Given this list of marker genes Vim, Ccl9, Ptn, Chl1, Nefl, Id4, Arhgdib, Rab38, Vcam1, Bgn, Adcyap1, C1s1, Fst, Klk1, Cyp1b1, Aebp1, Nol3, Stk17b, Irgm2, Pnliprp2, Tnfaip2, Nr2f1 (nuclear receptor subfamily 2, group F, member 1), Tspoap1, Fstl5, Tgm2, Serpina9, Galk1, Dusp26, Ccl2, Notch2, Map4, Adcy7, Hcn1, Msn, Ifit2, Dnm1, Sytl3, Iigp1, Stmn2, Lgals3, Anxa2, Col18a1, Cidea, Anxa1, Cdh11, Kcnip4, Camk4, Ly6h, Ccn4, Csf1, Serpinh1, Grm7, Dkk3, Vip, Slc15a3, Fbn1, Col6a1, Kcnd2, Gab1, Pygb, Parp3, Pmp22, Tgtp1, Efemp2, H2-Aa, Cxcl12, Htra1, Cnr1, Gbp3, Dclk1, Postn, Cacng5, Ceacam10, Lgals1, Akap12, Fads3, Elavl2, Efemp1, Scara3, Maf, Atf3 (NCBI Gene Id 11910), Hps1, H2-D1, Mcam, Ifitm1, Lyz1, Abcc3, Plcb4, Ntm, Tgfb2, Pcdh15, Rnase1, Dpt, Spink1, Thbs2, Rhoc, Snca, Nrsn1, Serpine2, Mical1, Adcyap1r1, Gsta4, Oplah, Acot7, Ptpro, Itga7, Blvrb, Epha5, Ifitm3, Nebl, Col5a2, Slc16a1, Zfp521, Smad3, Pla2g4a, Sycn, Ctsc, Timp2, Ndrg2, Septin4, Sparcl1, Snai2, Laptm5, Plxnd1 (NCBI Gene Id 67784), Ms4a4d, Fgf13, Gucy1a1, Cyba, Fgf14 (fibroblast growth factor 14), Stxbp5l, Apoe, Ass1, Itgb2, Ly6a, Sema4f, Sox2, Cplx1 (complexin 1), Slc6a15, Epb41l2, Gap43 (growth associated protein 43), Ifi203, Dnm3, Capg, Col3a1, Procr, Uchl1, Tmem47, Meis2, Prkg2, Sncg, Cxcl13, Scarf2, Rbfox1, Thy1, Mmp14 (NCBI Gene Id 17387), C1qb, Rbms3, Cacna2d3, Sv2b, Lyz2, Egr3, Tgfb3, Serpinb1a, Phox2b, Zfhx4, Egr2 (early growth response 2), C1qc, Fabp7, Amy1, Sdc1, Pcolce (NCBI Gene Id 18542), Rab6b, Rest, Nsg2 (neuron specific gene family member 2), Cnn2, here is a description of the gene set: Heterozygous HNF1A mutations cause pancreatic-islet beta-cell dysfunction and monogenic diabetes (MODY3). Hnf1alpha is known to regulate numerous hepatic genes, yet knowledge of its function in pancreatic islets is more limited. We now show that Hnf1a deficiency in mice leads to highly tissue-specific changes in the expression of genes involved in key functions of both islets and liver. To gain insights into the mechanisms of tissue-specific Hnf1alpha regulation, we integrated expression studies of Hnf1a-deficient mice with identification of direct Hnf1alpha targets. We demonstrate that Hnf1alpha can bind in a tissue-selective manner to genes that are expressed only in liver or islets. We also show that Hnf1alpha is essential only for the transcription of a minor fraction of its direct-target genes. Even among genes that were expressed in both liver and islets, the subset of targets showing functional dependence on Hnf1alpha was highly tissue specific. This was partly explained by the compensatory occupancy by the paralog Hnf1beta at selected genes in Hnf1a-deficient liver. In keeping with these findings, the biological consequences of Hnf1a deficiency were markedly different in islets and liver. Notably, Hnf1a deficiency led to impaired large-T-antigen-induced growth and oncogenesis in beta cells yet enhanced proliferation in hepatocytes. Collectively, these findings show that Hnf1alpha governs broad, highly tissue-specific genetic programs in pancreatic islets and liver and reveal key consequences of Hnf1a deficiency relevant to the pathophysiology of monogenic diabetes. Mouse Gene Set: SERVITJA_ISLET_HNF1A_TARGETS_UP Genes up-regulated in pancreatic islets upon knockout of HNF1A. studied in species Mus musculus from publication Servitja JM, Pignatelli M, Maestro MA, Cardalda C, Boj SF, Lozano J, Blanco E, Lafuente A, McCarthy MI, Sumoy L, Guigó R, Ferrer J (PMID 19289501)